The following is a description of a gene set: studied in species Mus musculus Genes predicted to be targets of miRBase v22 microRNA mmu_miR_183_3p in miRDB v6.0 with MirTarget v4 prediction scores > 80 (high confidence targets). Mouse Gene Set: MIR_183_3P from publication Chen Y, Wang X (PMID 31504780), and this is the list of marker genes: Tmed7, Umod, Nol4 (NCBI Gene Id 67506), Spata6l, Clec4d, Or5m3b, Azin1, Rps20, Pter, Vcan, A630001G21Rik, Usp38, Fzd3, Stradb, Pde10a, Mtarc2, Aadacl2, Zfp874a, Meig1, Negr1, Sprr2a1, Crlf2, Erlec1, Phlpp2, Ppp3cb, Edem3, Asb7, Eif4g1, Vcpip1, Fut9, Tmpo, Myt1, Peg10, Ccng2, Ppp4r3c2, Scn3a, Fam168a, Wdr43, Acadm (acyl-Coenzyme A dehydrogenase, medium chain), Gria3, Ccni, Rex2, Castor2, Cdk13, Scn2a, Esp16, Styx, B4galt6, Esp15, Fndc3a, Rnf2, Serpine3, Zrsr2, Cxcl9, Trappc2, Spam1, Cep350, Utp11, Diaph2, Cdkn1b, Tnfrsf11b, Chic1, Sfrp2, Nrk, Pou3f4, Zfp980, Ms4a18, Hs3st3b1, Akirin1, Iho1, Klhl7, Endov (NCBI Gene Id 338371), Flvcr2, Calcr, Srsf1, Rdh19, Ppp2r5c, Apol7b, Nr2c2, Zfp65, Btbd8, Zfpm2, Kif20b, Fstl5, Trpc5os, Ctps2, Gldc, Eif5a, Gxylt1, Cyp26b1, Mdga2, Osgin2, Siah1a, Uqcrc2 (NCBI Gene Id 67003), Gins2, Zfp268, Adhfe1, Myo6, Tmem255a, Nfs1, Prkar2b, Ebf1, Mfsd14a, Ralgps1 (NCBI Gene Id 99118), Luc7l3 (LUC7-like 3 (S. cerevisiae)), Kctd8, St7l, Sult1d1, Sclt1, Lama2, Dhdh, Vcf1, Gtf2a1, Henmt1, Usp3, Spock1, Nfyb, Kansl1l, Gpr141b, Usp32, Scfd2, Mmrn1, Zfp600, Mon2, Sprr2a2, Gid8, Lingo1, Zfp516, Rbm34, Mrc1, Apol7e, Plcl1, Rab5c, Il17f, Prkaa2, Myo19, Ctnnb1, Kif3c